The following is a description of a gene set: A tetrasaccharide linker sequence is required for GAG synthesis species: Mus musculus Mouse Gene Set: REACTOME_A_TETRASACCHARIDE_LINKER_SEQUENCE_IS_REQUIRED_FOR_GAG_SYNTHESIS, and this is the list of marker genes: Bcan, Gpc4, Sdc4, B3galt6, Xylt2, Sdc1, Gpc6, Sdc3, Vcan, Sdc2, Cspg5, Cspg4, Gpc1 (glypican 1), Gpc3, Gpc5, Uxs1, B4galt7 (beta-1,4-galactosyltransferase 7), Agrn, Gpc2, Bgn, Xylt1, B3gat3, B3gat1, B3gat2, Dcn